The following is a description of a gene set: 50 most interesting genes up-regulated in the pancreatic cancer cell lines (AsPC1, Hs766T, MiaPaCa2, Panc1) but not in the non-neoplastic cells (HPDE) by decitabine (5-aza-2'-deoxycytidine). Human Gene Set: SATO_SILENCED_BY_METHYLATION_IN_PANCREATIC_CANCER_2 To identify potential targets for aberrant methylation in pancreatic cancer, we analyzed global changes in gene expression profiles of four pancreatic cancer cell lines after treatment with the demethylating agent 5-aza-2'-deoxycytidine (5Aza-dC) and/or the histone deacetylase inhibitor trichostatin A. A substantial number of genes were induced 5-fold or greater by 5Aza-dC alone (631 transcripts), trichostatin A alone (1196 transcripts), and by treatment with both agents (857 transcripts). Four hundred and seventy-five genes were markedly (>5-fold) induced after 5Aza-dC treatment in pancreatic cancer cell lines but not in a nonneoplastic pancreatic epithelial cell line. The methylation status of 11 of these genes was examined in a panel of 42 pancreatic cancers, and all 11 of these genes were aberrantly methylated in pancreatic cancer but rarely, if any, methylated in 10 normal pancreatic ductal epithelia. These genes include UCHL1 (methylated in 100% of 42 pancreatic cancers), NPTX2 (98%), SARP2 (95%), CLDN5 (93%), reprimo (86%), LHX1 (76%), WNT7A (71%), FOXE1 (69%), TJP2 (64%), CDH3 (19%), and ST14 (10%). Three of these genes (NPTX2, SARP2, and CLDN5) were selected for further analysis in a larger panel of specimens, and aberrant methylation of at least one of these three genes was detectable in 100% of 43 primary pancreatic cancers and in 18 of 24 (75%) pancreatic juice samples obtained from patients with pancreatic cancer. Thus, a substantial number of genes are induced by 5Aza-dC treatment of pancreatic cancer cells, and many of them may represent novel targets for aberrant methylation in pancreatic carcinoma. species: Homo sapiens from publication Sato N, Fukushima N, Maitra A, Matsubayashi H, Yeo CJ, Cameron JL, Hruban RH, Goggins M (PMID 12839967), and this is the list of marker genes: CSF1, BNIP3, PAX6 (NCBI Gene Id 5080), NEFH, ST14, MATN1, IL1R1, PLAT, SFRP1, FOXE1, HOXA1, XAGE1B, GAGE12G, CACNA1G, TJP2, RPRM, TES, TNFRSF25 (TNF receptor superfamily member 25), TNF, CDH3, IGF2, ANGPT2, TP53I11, CSF2, STAG3, GAGE1, ISG20, CCNE2, JPH3, SMARCA1 (NCBI Gene Id 6594), PDYN, WNT7A, KLK10, UCHL1, PLEK2, LHX1, BARD1, CDKN1A, TIMP3, BST2, NPTX2, IFI6, SFN, CDKN1C, CLDN5, LDOC1, MAGED4B (NCBI Gene Id 81557)